Given this list of marker genes ETV5, GM2A, GTDC1, OPN3, STAU2, BCL2L1, ACYP2, SPINK2, TTYH2, MRPL46, FBXW2, TSHR, ENSG00000280119, ALDH1A2, GSTCD, DNTT, MACROD1, PSMD9, NAA50, NINJ2, PAG1, PRSS2 (NCBI Gene Id 93431), GALNT6, CHRNA3, CNOT6L, DUSP7, PIGN, UBE2V2, CDH4, GOLGA7, FLI1, PPP3CB, MPPED2, TMEM225B, SHTN1, SLC40A1, ABCG1, PDF, ARPP21 (cAMP regulated phosphoprotein 21), LAMP3, TFDP2, FAM98A, SLIT1, SCFD2, CTSG (cathepsin G), UQCRC2, C9, RCSD1, SFR1, TIMP2, TMED5, ARHGAP19, TICAM2, BICD1, FA2H, ASF1B, MZB1, SYK (spleen associated tyrosine kinase), USP7-AS1, C4orf3, SGPP1, here is a description of the gene set: from publication Grabarczyk P, Przybylski GK, Depke M, Völker U, Bahr J, Assmus K, Bröker BM, Walther R, Schmidt CA (PMID 17173069) Human Gene Set: GRABARCZYK_BCL11B_TARGETS_DN Genes down-regulated in Jurkat cells (transformed T lymphocytes) after knockdown of BCL11B by RNAi. studied in species Homo sapiens The B-cell chronic lymphocytic leukemia (CLL)/lymphoma 11B gene (BCL11B) encodes a Krüppel-like zinc-finger protein, which plays a crucial role in thymopoiesis and has been associated with hematopoietic malignancies. It was hypothesized that BCL11B may act as a tumor-suppressor gene, but its precise function has not yet been elucidated. Here, we demonstrate that the survival of human T-cell leukemia and lymphoma cell lines is critically dependent on Bcl11b. Suppression of Bcl11b by RNA interference selectively induced apoptosis in transformed T cells whereas normal mature T cells remained unaffected. The apoptosis was effected by simultaneous activation of death receptor-mediated and intrinsic apoptotic pathways, most likely as a result of tumor necrosis factor-related apoptosis-inducing ligand (TRAIL) upregulation and suppression of the Bcl-xL antiapoptotic protein. Our data indicate an antiapoptotic function of Bcl11b. The resistance of normal mature T lymphocytes to Bcl11b suppression-induced apoptosis and restricted expression pattern make it an attractive therapeutic target in T-cell malignancies.